Given this list of marker genes LARP1, CD200, TRIP12, AIF1, DNAJC2, STARD6, STXBP3, MTARC2, HOOK2, CPEB2, TMEM63B, STX2 (NCBI Gene Id 6808), ABCB1, COX18, TNPO2, ITGA4, NFKBIE, BMI1, NRBP1, JDP2, BBX, THRAP3, UAP1, CD164, SAP30, LAP3 (NCBI Gene Id 5186), RHOC, CRYGB, KARS1, NFKBIA, SLAMF1, SLC7A8, IL4I1, SIN3A, EBI3, ZNFX1, ENDOD1, CDC27, TMEM30A, FUT8 (fucosyltransferase 8), LAPTM4A, PHF21A, HIVEP1, VCAM1, FANCA, STX8, LPXN (NCBI Gene Id 9404), AVL9, WDR48, PRM3, PSME1, CD274, CYP1A1, GSTM2, NR4A2, DHPS, GTPBP2, TPRA1, SERPINA3, ICAM2, PPP2R2A, NUBP2, IL21R, ARHGEF2, IL2RG, KAT6A (NCBI Gene Id 7994), POGLUT1, ADPRH, SERPINE2, COL1A2 (NCBI Gene Id 1278), NOTCH3, CCDC80, MYL3, GTPBP6, EXTL1, CYTH1, SGK1, PDE6G, HBP1, CFLAR, H1-2, CCR7, GNPTAB, SERTAD1, CASP7, TMCO4 (transmembrane and coiled-coil domains 4), PSMB6, TOX4, HOMER1, PNRC1, SCARB2, SPOP, SEH1L, GNL1, PLEKHS1, CDKN1A, IFFO2, MORC3, CLIC4, SELENOT, ASB13, ST6GALNAC6, TECPR1, TXN, DNAJB6, TBC1D13 (TBC1 domain family member 13), LGALS3BP, EHD4, TMEM229B (NCBI Gene Id 161145), EPSTI1, NR2E3, TMEM53, AIM2, MAPK6, PDSS1, TNFSF8, ZBTB2, GFRA4, NUDT13, ITK, PIAS1, SP4, DOP1B, IL10RA, EMILIN3, COL22A1, RAB3IP, MISP, HCRT, CRBN, TMEM243, SDC4, PLD4, SH3BP1, CNN2, TPX2, IL12RB1, ACYP2 (acylphosphatase 2), TRAF1, SLC9A8, HMG20B, UBL7, PIK3R2, NR1D2, PPP1R15A, PLK2, OGFRL1, WDFY1, PDK3, MMP16, DTD1, BLTP1, CPTP, RNPEP, VPS9D1, TNFRSF1A, CCL17, CASP3, C14orf180, CFAP184, STAP2, CLRN3, USP25, FNBP4, KLF6, CST3 (cystatin C), POU3F2, INSL6, KREMEN1, NSUN4, PSME2 (NCBI Gene Id 5721), WNT7A, ABHD6 (NCBI Gene Id 96026), WNK2, NFKBIB, M1AP, USP15, CSRP1, RIOX2, DYNC1I2, MAN2A1 (NCBI Gene Id 4124), MTMR2, KLK10, AKR1C3, HCN2, ANKIB1, MYD88, TLR6, PGS1, IL17RC, STX4, CRYGS, TAGLN2, PDLIM5, CCN4, MICAL2, AP2B1, CMTR1, HK1, SERPINE1, here is a description of the gene set: Genes up-regulated in comparison of dendritic cells (DC) stimulated with LPS (TLR4 agonist) at 12 h versus DC cells stimulated with Pam3Csk4 (TLR1/2 agonist) at 12 h. mouse primary BMDCs were stimulated with tlr ligands and gene expression changes were profiled on Affymetrix arrays Human Gene Set: GSE17721_LPS_VS_PAM3CSK4_12H_BMDC_UP species: Homo sapiens from publication Amit I, Garber M, Chevrier N, Leite AP, Donner Y, Eisenhaure T, Guttman M, Grenier JK, Li W, Zuk O, Schubert LA, Birditt B, Shay T, Goren A, Zhang X, Smith Z, Deering R, McDonald RC, Cabili M, Bernstein BE, Rinn JL, Meissner A, Root DE, Hacohen N, Regev A (PMID 19729616)